Given this list of marker genes H4C13, ACD, MCM5, TNKS, NSL1, DYNC1I1, WAPL, UPF1, TERB2, SMG6, MTBP, NSMCE2, PBRM1, CENPX, RAD50, SPOUT1, CENPV (NCBI Gene Id 201161), THOC1, CENPB, H2BC3, KIF18A, NUP107, RASSF2, TPR, HDAC2, DYNLL1, EZH2, PLK1, FBXW11, ZBTB48, BRCA2, KAT8, SMC3, H2AX, C9orf78, SUV39H2, SYCP3, SUN2, AURKB, RAD21, KDM1A, ACTB, FMR1, H4C6, H4C4 (NCBI Gene Id 8360), SP100, POLD1, BUB3, CDK1, ERCC1, STAG2, PDS5B, KAT2B, LUZP1, H3-3A, DNMT3A, XRCC3, PPP1R12A, NSMCE4A, CENPA, MSH2, CDT1, NUF2, SSB, MTCL1, BAZ1B, MIS18A, CENPS, SPC25, DCTN3, CLASP2, CCNB1, CDCA8, APC, ARID2, DYNC1LI2, SNAI1, NUP37, SYCP2L, DCTN6, ORC4, TERF2IP, ZWINT, TEX14, SMCHD1, KIF2B, ORC3, SGO2, DHX36, H2BC11, H4C12, SPDL1, PPP2CA, SIN3A, TERB1, DNA2, CHMP2B, NBN, CKAP5, ZNF330 (zinc finger protein 330), EID3, THOC7, RANGAP1, THOC5, ALYREF, SMARCB1, ZW10, NCAPD2, MCM7, KASH5, CEBPB, SLX4 (SLX4 structure-specific endonuclease subunit), SKA2, ZNF618, SIRT6, MCM6, XRCC1, MAD1L1, PHF6, GAR1, PLK3, CDK2, KNTC1, CHEK1, HNRNPU, H4C3, CENPN, PSEN1 (NCBI Gene Id 5663), PPP2R5A, PRKDC, CENPF, MCM2, CENPM (centromere protein M), RBBP4, ERCC6L (ERCC excision repair 6 like, spindle assembly checkpoint helicase), CHMP4BP1, ESCO2, PPP2R1A, NUDCD2, MTA2, CHD4, TERF2, CHMP7, PPP2CB, ZNF276, RECQL4, RBBP7, CBX3, UVRAG, SMARCC2, RNF8, CENPI, NUP43, H4C1 (H4 clustered histone 1), NSMCE1, CENPE, PTGES3, SUGT1, HNRNPA2B1, TELO2, KIF22, CENPC, H4C15, MCM3, TNKS2, NUP133, RAD51AP1, SMARCC1, DCTN5, SMARCE1, KDM4D, CHEK2 (checkpoint kinase 2), TRAPPC12, H2AC1, ORC5, SMC6, DCTN1, H3-3B, H2AC8, SS18L1, KANSL1, H2BC1 (NCBI Gene Id 255626), CENPW, BOD1L2, ORC2, POLR2B, CENPQ, XPO1, CHMP3, NHP2, H4C8, DAPK3, ATM, SMC4, WRN, THOC2, FIRRM, FLYWCH1, TINF2, CHMP4C (charged multivesicular body protein 4C), PPP1CA, ATRX, STAG1, PML, XRCC6, SETX, KAT5, DSN1, NCAPD3, CENPL, KDM4A, TEN1, NSMCE3, DNMT1, HJURP, TOX4, SPDYA, SUN1 (NCBI Gene Id 80226), MAD2L1, H4C14, ANAPC16, KDM4C, ZWILCH, TFIP11, PLK5, SEC13, CDCA5, MRE11, WRAP53, STN1, CHMP5, NGDN, KMT5C, CENPO, THOC3, CENPT, TERT, SEPTIN2, NUP160, EZH1, SKA3, AURKA, FEN1, PARP1, LRWD1, KAT7, AHCTF1, SPO11, SKA1, SEPTIN7, ERCC4, CENPP, PCNA, ITGB3BP, BUB1, PPP1CB, PMF1, HELLS, NDE1, HSF1, SMARCA5, THOC6, HMBOX1, MEIKIN, PRP4K, POLE3, ACTL6A, IKZF1, BUB1B, PHF2, SUV39H1, DCTN4, LIG4, CHAMP1, WDR82, DCTN2, GTF2B, CSNK1A1, MIS12, ZNF207, SYCP2, H4C5, NLRP2, PINX1, SEPTIN6, TERC, GPATCH11, NUP85, SGO1, KMT5B, CHMP1B, SMARCA4, DCLRE1B, PSEN2, ATR, ACTL6B, NEK2, BLM, ZSCAN4, KNSTRN, BIRC5, SMARCD1, FBXO28, RPA2, CDC73, NAT10, RPA4, SMC1B, ORC1, PIF1, NDEL1, CTC1, SIRT2, CLASP1 (NCBI Gene Id 23332), SMARCD2, DAXX, PAFAH1B1, RPA1, TP53BP1, ZNF827 (zinc finger protein 827), SMC5, MACROH2A1, TERF1, NCAPG, RTEL1, MEAF6, CBX5, POT1, PPP1R10, AURKC, ATF7, NDC80, SPC24, CDC20, SMC1A, OIP5, PURA, BAZ1A, DMC1, TTK, PDS5A, RCC2, DDB1, DYNLT3, CENPK, XRCC5, GATAD2B, DSCC1, CFDP1, APEX1, TRIOBP, ZBTB10, SLF2, CTCF (NCBI Gene Id 10664), KNL1, H4C9, SYCP1, TEP1 (NCBI Gene Id 7011), SUMO3, ERCC6L2, PPP2R5C, REC8, H3-4, MIS18BP1, CHMP4A, MEN1, MAJIN, CHMP4B, H4C2, PKHD1, MACROH2A2, SLF1, SPAG5, DOT1L, SEH1L, STAG3, PPP1CC, NABP1, TOP2A, CENPU, HAT1, PLK2, NUP98, NABP2, CHRAC1, UHRF2, CBX1, BOD1, CLIP1, H4C16, PHF10, RAD17, RAD51D, H4C11, INCENP, CENPH, CHMP1A, WRNIP1, DYNC1LI1, BRD7, CHMP6, MCM4, RAD51, H2AC4, H2BW1, RIF1, CHMP2A, KIF2C, LRIF1 (ligand dependent nuclear receptor interacting factor 1), here is a description of the gene set: Any subdivision of a chromosome along its length. Human Gene Set: GOCC_CHROMOSOMAL_REGION studied in species Homo sapiens